Given this list of marker genes Rab3gap1, Hap1, Nkx2-1, Sema3e, Srd5a2, Bax, Nhlh2, Nrp1, Otp, Pitx2, Plxna1, Ubb, Sox3, Nrp2 (NCBI Gene Id 68752), Pou3f2, Sema3a, Crh, Prdm13, Rax, Ncoa1, Nkx2-6, Prop1, Foxb1, Uqcrq, Bloc1s6, Gsx1, Plxna3, Ctnnb1, Ndnf, here is a description of the gene set: The progression of the hypothalamus region of the forebrain, from its initial formation to its mature state. Mouse Gene Set: GOBP_HYPOTHALAMUS_DEVELOPMENT studied in species Mus musculus